Given this list of marker genes EXOC4, WNT11, WNT3A, LEF1, FOXC2, FOXC1, WNT5A, here is a description of the gene set: The process that gives rise to the paraxial mesoderm. This process pertains to the initial formation of the structure from unspecified parts. species: Homo sapiens Human Gene Set: GOBP_PARAXIAL_MESODERM_FORMATION